The following is a description of a gene set: Human Gene Set: GOBP_PYRIMIDINE_RIBONUCLEOTIDE_CATABOLIC_PROCESS The chemical reactions and pathways resulting in the breakdown of a pyrimidine ribonucleotide, a compound consisting of nucleoside (a pyrimidine base linked to a ribose sugar) esterified with a phosphate group at either the 3' or 5'-hydroxyl group of the sugar. studied in species Homo sapiens, and this is the list of marker genes: ENTPD5, NT5C (NCBI Gene Id 7370), UPB1, ENTPD4, DPYS, UPP1, DPYD, ENTPD7, UPP2